The following is a description of a gene set: Human Gene Set: GOBP_CGMP_METABOLIC_PROCESS The chemical reactions and pathways involving cyclic GMP, guanosine 3',5'-phosphate. studied in species Homo sapiens, and this is the list of marker genes: NPR2, PDE1A, GUCY2D, PDE5A, NPPA (NCBI Gene Id 90230), PDE2A, RORA (RAR related orphan receptor A), GUCY1B1, GUCY2C, NPPC, PDE10A, PDE9A, NPR1, NPPB (NCBI Gene Id 4879), GUCY1A1, GUCY1A2, GUCY2F